The following is a description of a gene set: CD25+ regulatory T cells develop in the thymus (nTregs), but may also be generated in the periphery upon stimulation of naive CD4 T cells under appropriate conditions (iTregs). The mechanisms that regulate the generation of peripheral iTregs are largely unknown. We used microarrays to gain insights into the molecular program of extrathymic Treg development. Human Gene Set: GSE24634_TEFF_VS_TCONV_DAY3_IN_CULTURE_UP from publication Prots I, Skapenko A, Lipsky PE, Schulze-Koops H (PMID 21347372) species: Homo sapiens Genes up-regulated in comparison of CD25+ T effector cells treated with IL4 at day 3 versus untreated CD25- T cells at day 3., and this is the list of marker genes: MFHAS1, STAP1, EIF2B2, EIF6, STMN1, CLPP, SHCBP1, RAD51, TUBB, BLMH, GLRX5, GZMB, R3HDM1, KIF3B, RAB27A, GFPT2, ERCC3, DNAAF5, TTF1, KIF20A, ODC1, NLE1, TAF5, RWDD1, RAB8B, PUS7 (pseudouridine synthase 7), POLDIP2, MREG, UAP1, TOMM34 (translocase of outer mitochondrial membrane 34), PTS, SNRNP25, BUB1B, MRPL9, TNIP3, MALT1, LONP1, INPP5F, CFLAR, CENPS, EIF2B4, PPP1R14B, NCAPD3, ZNF593, MTHFD1, CENPM, CKB, BCL2, CEP43, PIMREG, MYO5C, MRPS34 (mitochondrial ribosomal protein S34), PHTF2, PON3, MTX1, EMC6, RGS16, PSMG1, SH2D2A, TYMS, MCAT, MAGOHB, CAD, SLC39A14, SUPT16H, LBHD1, CKAP2, PBK, CIAO1, SMC2, EVI5, PLPP1, ENDOD1, GINS3, VRK1, NAA10, BCL2A1, PTP4A3, ZWINT, BARD1, DPP4, TMEM106C, POLR1C, PTBP1, PTRH2, YBX3, COX17, IMP4, PAF1, NTHL1, CTLA4, PRC1, FABP5, FBXL18 (NCBI Gene Id 80028), RNASEH1, EED, SLAMF1, PTPRK, TPI1, PCNA, FANCE, CHN1, TUBA1B, TTC4, MPHOSPH10, AFG3L2, KIF15, LTB, EIF3J, FAM98A, SLC25A14, PUM3, REXO4, GPN2, STAT4, EZH2, SPRED2, CTPS1, DBF4, ARHGAP19, TBRG4, MAPKAPK3, NCAPH, TTF2, MARCKSL1, OSBPL3, NOP16, POLRMT, HINT1, KIF5C, WDR77, SKP2, EIF2D, NCL, MNAT1, UCK2, TIMM13 (NCBI Gene Id 26518), PPAN (NCBI Gene Id 84997), JPT2, FUT8, TOP2A, KPNB1, TSR3 (TSR3 ribosome maturation factor), TK1, PAICS, SEPTIN11, WDR3, CCL22, SNU13, SLC25A5, CCNB2, DDX52, DTYMK (NCBI Gene Id 9102), RPA3, YARS2, INPP4B, MAOA, TTLL12, GFUS, CEP97, ANAPC1, CENPA, SMC4, ESPL1, CSE1L, RRAS2, CYB5R2, SMC6, CDT1, ATP5MC1, UBE2C, MRPL12, DHX30, BRIX1, RRP1, TIPIN, CDK1, IRF4, FANCI, MRTO4, TTI2, TMEM97, C12orf43, ZNF85, BUB3 (BUB3 mitotic checkpoint protein), STAMBP, F5, EBI3, GRPEL1, IFNG, AVEN, SRPK1 (NCBI Gene Id 6732), STK39, RRP8, DUT, PMAIP1, POLE2, P2RX5, TUBA1C, PHLPP2